Given this list of marker genes Plxna3, Fes, Pak3, Sema3a, Fyn, here is a description of the gene set: Reactome Pathway: Sema3A PAK dependent Axon repulsion electronically inferred by orthology from the curated human pathway species: Mus musculus This event has been computationally inferred from an event that has been demonstrated in another species.<p>The inference is based on the homology mapping from PANTHER. Briefly, reactions for which all involved PhysicalEntities (in input, output and catalyst) have a mapped orthologue/paralogue (for complexes at least 75% of components must have a mapping) are inferred to the other species. part of: Semaphorin interactions